The following is a description of a gene set: species: Mus musculus Any process that activates or increases the frequency, rate or extent of protein localization to nucleolus. Mouse Gene Set: GOBP_POSITIVE_REGULATION_OF_PROTEIN_LOCALIZATION_TO_NUCLEOLUS, and this is the list of marker genes: Cacnb4, Npm1, Pinx1, Tert, Mcrs1, Nmd3